Given this list of marker genes IL15, IRF9, TRGC1, IRF7, OAS1, here is a description of the gene set: Aging is associated with hyporesponse to vaccination, whose mechanisms remain unclear. In this study hepatitis B virus (HBV)-naive older adults received three vaccines, including one against HBV. Here we show, using transcriptional and cytometric profiling of whole blood collected before vaccination, that heightened expression of genes that augment B-cell responses and higher memory B-cell frequencies correlate with stronger responses to HBV vaccine. In contrast, higher levels of inflammatory response transcripts and increased frequencies of pro-inflammatory innate cells correlate with weaker responses to this vaccine. Increased numbers of erythrocytes and the haem-induced response also correlate with poor response to the HBV vaccine. A transcriptomics-based pre-vaccination predictor of response to HBV vaccine is built and validated in distinct sets of older adults. This moderately accurate (area under the curve ~65%) but robust signature is supported by flow cytometry and cytokine profiling. This study is the first that identifies baseline predictors and mechanisms of response to the HBV vaccine. from publication Fourati S, Cristescu R, Loboda A, Talla A, Filali A, Railkar R, Schaeffer AK, Favre D, Gagnon D, Peretz Y, Wang IM, Beals CR, Casimiro DR, Carayannopoulos LN, Sékaly RP (PMID 26742691) Human Gene Set: FOURATI_BLOOD_TWINRIX_AGE_65_83YO_POOR_RESPONDERS_VS_RESPONDERS_0DY_NETWORK_INFERENCE_UP studied in species Homo sapiens Genes up-regulated in blood poor responders vs responders in seniors (65-83) (poor responders) after exposure to Twinrix, time point 0D. Comment: Networks were inferred for the BioAge module 1 combined to the 15-gene signature and the BioAge module 16 combined to the 15-gene signature, respectively.